The following is a description of a gene set: studied in species Mus musculus A preribosomal complex consisting of 27SA, 27SB, and/or 7S pre-rRNA, 5S rRNA, ribosomal proteins including late-associating large subunit proteins, and associated proteins; a precursor of the eukaryotic cytoplasmic large ribosomal subunit. Mouse Gene Set: GOCC_PRERIBOSOME_LARGE_SUBUNIT_PRECURSOR, and this is the list of marker genes: Wdr74, Bop1 (NCBI Gene Id 97992), Mak16, Mdn1, Rpf1, Mrto4, Ftsj3, Casp8, Nsa2, Ppan, Rrp15, Nip7, Ebna1bp2, Zfp622, Pes1, Rrs1, Noc2l, Wdr12